Given this list of marker genes Slc25a42, Entpd2, Entpd5, Cant1, Entpd1, Alpl, Pgp, here is a description of the gene set: Mouse Gene Set: GOMF_ADP_PHOSPHATASE_ACTIVITY species: Mus musculus Catalysis of the reaction: ADP + H2O = AMP + phosphate + H+.